The following is a description of a gene set: Human Gene Set: REACTOME_COBALAMIN_CBL_METABOLISM Cobalamin (Cbl) metabolism species: Homo sapiens, and this is the list of marker genes: MMAB, MMAA, MTRR, MTR, MMADHC, MMACHC, MMUT